The following is a description of a gene set: studied in species Mus musculus Any process that activates or increases the frequency, rate or extent of attachment of spindle microtubules to kinetochore involved in mitotic sister chromatid segregation. Mouse Gene Set: GOBP_POSITIVE_REGULATION_OF_ATTACHMENT_OF_MITOTIC_SPINDLE_MICROTUBULES_TO_KINETOCHORE, and this is the list of marker genes: Becn1, Kat5, Aurkb, Birc5, Kat2b, Cdca8, Hnrnpu, Incenp